Given this list of marker genes TET2, TDG, TET1, TET3, here is a description of the gene set: species: Homo sapiens About 2-6% of all cytosine residues and 70-80% of cytosine residues in CG dinucleotides in mammalian cells are methylated at the 5 position of the pyrimidine ring. The cytosine residues are methylated by DNA methyltransferases after DNA replication and can be demethylated by passive dilution during subsequent replication or by active modification of the 5-methylcytosine base. Cytosine demethylation is developmentally regulated: one wave of demethylation occurs in primordial germ cells and one wave occurs by active demethylation in the male pronucleus after fertilization.<br>Some mechanisms of active demethylation remain controversial, however progressive oxidation of the methyl group of 5-methylcytosine followed by base excision by thymine DNA glycosylase (TDG) has been reproducibly demonstrated in vivo. Ten-eleven translocation proteins TET1, TET2, and TET3 are dioxygenases that first oxidize 5-methylcytosine to 5-hydroxymethylcytosine (5-hmC), which is found in significant quantities and specific genomic locations in stem cells and neurons. TET proteins can further oxidize 5-hmC to 5-formylcytosine (5-fC) and then 5-carboxylcytosine (5-caC). G:5-fC and G:5-caC base pairs are recognized by TDG, which excises the 5-fC or 5-caC and leaves an abasic site.<br>TET1 in mouse is expressed in neurons and its expression depends on neuronal activity. TET1 is also found in embryonic stem cells and in primordial germ cells of mice, where it plays a role in erasure of imprinting. TET3 is expressed in oocytes and zygotes of mice and is required for demethylation in the male pronucleus. TET2 is the most highly expressed TET family protein in hemopoietic stem cells and appears to act as a tumor suppressor. TET2 is also expressed in embryonic stem cells. part of: Epigenetic regulation of gene expression Reactome Pathway: TET1,2,3 and TDG demethylate DNA